The following is a description of a gene set: Mouse Gene Set: GOBP_REGULATION_OF_HAIR_CYCLE Any process that modulates the frequency, rate or extent of the cyclical phases of growth (anagen), regression (catagen), quiescence (telogen), and shedding (exogen) in the life of a hair. studied in species Mus musculus, and this is the list of marker genes: Nfatc1, Foxn1, Nipbl, Tgfb2, Tradd (TNFRSF1A-associated via death domain), Fa2h, Inhba, Eps8l3, Gal, Tnf, Hpse, Krt17, Smad4, Tert, Cdh3, Gsdma3, Clock, Ngfr, Dkk4, Fermt1, Numa1, Trpv3, Bmal1, Fst, Mysm1, Tsku, Per1, Msx2, Wnt5a (NCBI Gene Id 77565), Smo, Pkp3, Wnt10b